The following is a description of a gene set: Reactome Pathway: Sterols are 12-hydroxylated by CYP8B1 Cytochrome P450 8B1 (CYP8B1, sterol 12-alpha- hydroxylase) has a broad substrate specificity including a number of 7-alpha- hydroxylated C27 steroids. It is also involved in bile acid synthesis and is responsible for the balance between the formation of cholic acid and chenodeoxycholic acid. part of: Endogenous sterols studied in species Homo sapiens, and this is the list of marker genes: CYP8B1